Given this list of marker genes Msh2, Wrn, Pcna (proliferating cell nuclear antigen), Trex1, Atr, Msh6, here is a description of the gene set: species: Mus musculus Binding to a MutLalpha mismatch repair complex. Mouse Gene Set: GOMF_MUTLALPHA_COMPLEX_BINDING